Given this list of marker genes SBF2, H2AC25, VAPB, RBM22, CTDSP1, EPS8L1, CHMP3, NR1D2, ANGPTL3, MFHAS1, CKMT2, UVRAG, RHEB, CD300LD, NXPE1, CD48, FARP1, WDR26, ARAP3, SLC9A6, TACC2, MARCHF7, RPSA, SNX27, ALDOC, PADI4, HNRNPUL2, RALGAPA2, KCNK13, SMYD3, TOMM40L, GOLM1, SMARCAL1, RUFY3, RNPEPL1, ETV5, TMEM50A, AKIRIN2, SUN2, GUSB, FRY, NDUFS8, HERC1, SUPT20HL1, HADHB, USP19, HDAC6, SFRP4, NEDD4L, NFIA, SIAE, PHF14, ERP29, LPGAT1, PHLDA3, NCKIPSD, HYCC1, CDKL2, MRI1, PTGIS (prostaglandin I2 synthase), TTC21B (NCBI Gene Id 79809), CORO7, REEP3, STAT6, TTLL4, ELOVL5 (NCBI Gene Id 60481), RASGRF2, WBP1, PPP3CA, MSRB2, SLC7A6OS, SHQ1, RRM1, TOB1, CABIN1, SEPTIN6, IGF1, ERGIC1, RBM15, CHST14, PINK1, SLC8B1 (NCBI Gene Id 80024), ALDH1B1, FOS, TATDN3, RAB5C, CD63, IQSEC1, ATF1 (activating transcription factor 1), VGLL4, HELZ, FCGRT, HIC2, EIF4A2, NPAS4, ATF6, RANBP2, CARD11, UPRT, RRM2, TPD52, TGFBR1 (transforming growth factor beta receptor 1), DAP, TMEM70, TDRD5, RPL32, GCC2 (NCBI Gene Id 9648), LRRC27, ITSN2, DIDO1, MBD2, MOB3A, STRADA, POLA1, DIP2C, ACO1, DOCK10, ZBTB33, DYNC1I2, EHHADH (NCBI Gene Id 1962), LAPTM5, TRIM28 (tripartite motif containing 28), STAR, GALNT12, BIN3, CPEB4, ACAP2, MYOT, TMPO, IL3RA, SAMD8, NFIB, S100PBP, ILF3, SSBP2, SFPQ, MIR379, RMDN1, KCTD12, EFCAB12, IPO8, RALBP1, GALNT9, SLC12A9, NUB1, TMEM255A, RFX1 (regulatory factor X1), MOCOS, GMEB2, NOSTRIN, PSAP, PLEKHA2, FANCE, CHD3, KLC4, DNAJC5, DENND2A, KIF23, IDI1, MAP2K5, RAB40C, TMEM71, PSD4, DCTN5, HNRNPA0, CLIC1, ENTPD6, LPAR5 (NCBI Gene Id 57121), RANBP10, CDC25B, ST14, GIPC1, BTBD7, SDC2, RAP2B, BTBD2, FBXO3, CERS5, ADD3, here is a description of the gene set: Human Gene Set: GSE37301_HEMATOPOIETIC_STEM_CELL_VS_LYMPHOID_PRIMED_MPP_UP studied in species Homo sapiens from publication Ramirez K, Chandler KJ, Spaulding C, Zandi S, Sigvardsson M, Graves BJ, Kee BL (PMID 22608498) Genes up-regulated in hematopoietic stem cells versus lymphoid primed multipotent progenitors. Expression profiling of Rag2-deficient Ets1++ and Rag2-deficient Ets1-- mature NK cells and WT bone marrow progenitors, WT T cells, and WT Pro B cells